Given this list of marker genes Ltb (lymphotoxin B), Ifitm3, Tnfrsf17, Mmp9, Lcn2, Ell2, Serpina3g, B3galnt1, Cpe, Stat4, Reck, Ltb4r1, Maged1, H2-Q2, S100a9 (S100 calcium binding protein A9 (calgranulin B)), Il18r1, Ctsg, Zbp1, Mfsd4a, Tent5c, Ighg2c, Fads3, Hp, Ddx3y, Ifi207, Amy1, Isg20, Lpar4, Slfn4, Hook1, Tfec, Gbp8, Ighg2b, Mcpt4, Stfa1, Cpeb3, Itga1 (integrin alpha 1), Ctsw, Hdc, Ms4a4b, Fgl2, Mucl2, Ear1, Itk, Nbea (neurobeachin), Hba-a1, Pglyrp1, Fscn1, Gpr160, Armcx2 (NCBI Gene Id 67416), Igsf6, Abi3bp, Slfn1, S100a8, Scart1, Ifitm6, Lilrb4b, Trbc1, Trgc1, Crisp3, Igha, Cryba4, Zbtb20, Plaat3, Camp, Trdc, F2r, Ighg1, Gimap8, Eif2s3y, Elane, F2rl1, Wipi1, Chst1, Plin3, Rasgrp3, Speer1a, Igkv1-117, Nkg7, App, Cd9 (CD9 antigen), Fpr1, Oosp1, Armcx3, Mcpt8, Ccr2, Pawr, Tgfbi, Klrc1, Prtn3, Igkv6-15 (immunoglobulin kappa variable 6-15), Lrg1, 2310061I04Rik, Basp1, Osbpl3, Ighv2-5, Dcpp1, Zbtb16, Plscr1, Fyb1, Gramd1c, Gimap4, Afp, Cxcr6, Smr3a, Epcam, Cp, Igkv3-7, Cd3d (CD3 antigen, delta polypeptide), Spag6, Ccl5, Gpm6a, Spon1, Alcam, Igkv12-46, Itgal, Mpo, Chil3, Cacna1s, Lyz2, Slc25a24, Gbp6, C3, Prg2, Igkv15-103, ENSMUSG00000127189, Apol7c, Ifi202b, Ly6c1, Jchain, Ltf, Vav3, Xdh, Prlr, Ifi204, Cd177, Arhgap6, Il2rb, Cacna1h, Selenom (selenoprotein M), Rmdn2, Tmem176a, here is a description of the gene set: Top up-regulated genes from principal component 1 (PCA1) which captures variation between normal plasma cells and tumors arising from aberrant expression of BCL2L1 and MYC. Multiple myeloma is an incurable plasma cell malignancy for which existing animal models are limited. We have previously shown that the targeted expression of the transgenes c-Myc and Bcl-X(L) in murine plasma cells produces malignancy that displays features of human myeloma, such as localization of tumor cells to the bone marrow and lytic bone lesions. We have isolated and characterized in vitro cultures and adoptive transfers of tumors from Bcl-xl/Myc transgenic mice. Tumors have a plasmablastic morphology and variable expression of CD138, CD45, CD38, and CD19. Spectral karyotyping analysis of metaphase chromosomes from primary tumor cell cultures shows that the Bcl-xl/Myc tumors contain a variety of chromosomal abnormalities, including trisomies, translocations, and deletions. The most frequently aberrant chromosomes are 12 and 16. Three sites for recurring translocations were also identified on chromosomes 4D, 12F, and 16C. Gene expression profiling was used to identify differences in gene expression between tumor cells and normal plasma cells (NPC) and to cluster the tumors into two groups (tumor groups C and D), with distinct gene expression profiles. Four hundred and ninety-five genes were significantly different between both tumor groups and NPCs, whereas genes were uniquely different from NPCs in tumor group C and genes were uniquely different from NPCs in tumor group D. Similar to human myeloma, the cyclin D genes are differentially dysregulated in the mouse tumor groups. These data suggest the Bcl-xl/Myc tumors are similar to a subset of plasmablastic human myelomas and provide insight into the specific genes and pathways underlying the human disease. studied in species Mus musculus from publication Boylan KL, Gosse MA, Staggs SE, Janz S, Grindle S, Kansas GS, Van Ness BG (PMID 17483317) Mouse Gene Set: BOYLAN_MULTIPLE_MYELOMA_PCA1_UP